The following is a description of a gene set: species: Homo sapiens part of: DDX58/IFIH1-mediated induction of interferon-alpha/beta Reactome Pathway: TRAF3-dependent IRF activation pathway MAVS via its TRAF-interaction motif (TIM) directly interacts with TRAF3 and recruits TRAF3 to the signaling complex. TRAF3 acts as a scaffold for the assembly of a signaling complex composed of IKK epsilon/TBK1, leading to the activation of transcription factors IRF3/IRF7., and this is the list of marker genes: TRIM25, IKBKE, IRF3, EP300, CREBBP, MAVS, IFIH1, RIGI, TRAF3, rep, 1C, SIKE1, IRF7, M, TBK1, IFNB1, RNF135, TRIM4